The following is a description of a gene set: studied in species Homo sapiens Mechanoregulation and pathology of YAP/TAZ via Hippo and non-Hippo mechanisms Human Gene Set: WP_MECHANOREGULATION_AND_PATHOLOGY_OF_YAPTAZ_VIA_HIPPO_AND_NONHIPPO_MECHANISMS, and this is the list of marker genes: MAPK8, ITGB5, MAP4K5, ITGB3, ITGB7, TEAD3, WWTR1, MAP4K3, ITGB2, TEAD2, PAK6, MAP4K2, STK3, ACTC1, ITGB4, MAP4K4, MAPK9, PAK5, PAK3, ACTA1, PAK4, MAP4K1, SRC, ACTB, SGMS1, LATS1, SAV1, YAP1, BUB1B-PAK6, PAK2, CTNNA1, CTNNB1, PAK1, TEAD1, ITGB8, LIMD1, MST1, CDH1, NF2, ITGB1, ACTG1, ITGB6, ACTG2, YWHAQ, TEAD4, ACTA2, MAPK10 (mitogen-activated protein kinase 10)